The following is a description of a gene set: Mouse Gene Set: chr5C3 species: Mus musculus, and this is the list of marker genes: Gm19590 (predicted gene, 19590), Wdr19, Ppat, Gm25608, Chic2, Gsx2, Pdgfra (platelet derived growth factor receptor, alpha polypeptide), 1700071G01Rik, Cep135, Gm31049, Pea15b-ps, Gm15616, Ube2k, Dancr, Gm18593, Klhl5, Gm19560, 4930480C01Rik, Rasl11b, Gm26072, 1700025M24Rik, N4bp2, Tbc1d1, Gabra4, Arl9, Cwh43, Gm5297, Pgm2, 6720475M21Rik, Exoc1l, Gabrb1, Gm5867, Snora26, 0610040J01Rik, Tmem33, Gm6116, Gm6044, Gm22559, 5830416I19Rik, Apbb2, C030017G13Rik, Clock, 4930526M16Rik, Rhoh, Nwd2os, Gabra2, Usp46os1 (NCBI Gene Id 74299), Chrna9, Yipf7, C530043K16Rik, Gm43383, Txk, Srp72, Cnga1, D630030B08Rik, Gm15478, Scfd2, Gm43772, 4930425K10Rik, Tmem165, Gm43028, 1700019F05Rik, Slc10a4-ps, Gm23661 (NCBI Gene Id 115490305), Hopx, Olfr1401-ps1, Gm3822, Gm20647, Klf3, Igfbp7, Cracd (capping protein inhibiting regulator of actin), Dthd1, Shisa3, Gm34144, 9130230L23Rik, Noa1, Exoc1, Nipal1, 1700025A08Rik, A330058E17Rik (NCBI Gene Id 319553), Gm22273, Kit, Gm34583, Guf1, Usp46, Gm22929, Aasdh, Gm15824, Gm19583, 2310040G07Rik, Commd8, Gm42632, Spink2, Gm32780, Gm15831, Gm7494 (NCBI Gene Id 677181), Gabrg1, Apc-ps1, G6pd2, Sgcb, Smim14 (small integral membrane protein 14), Gm23605 (NCBI Gene Id 115486322), Polr2b, Uchl1os, A730089K16Rik, Gm43838, Bend4, N4bp2os, Chaer1, Mir574, Gm3687, 4930589O11Rik (NCBI Gene Id 78214), Rfc1, Gm24502, Tlr1, C330024D21Rik, Rest, Gm24399, Gm23067 (predicted gene, 23067), Gm6517, Gm6051, Gm20072, Nfxl1, Gm19060, Fryl, Kdr, Mir5098, Tmem156, Hopxos, Limch1, 1700126H18Rik, Lrrc66, Arap2, 3110031N09Rik, Gm26044, Grxcr1, 1110003F10Rik, Gm34648, Gm40309, D130004A15Rik, Gm34411, 1700027F09Rik, Ociad1, 1700112J05Rik, Gm9870, Ugdh, Fip1l1, 4933408A14Rik, Gm2040, Mir7025, Gm18345, Paics, Gm26761, Spmap2l, C230096K16Rik, Gm38562, Lias, Lnx1, Gm15617, 1700017L05Rik, Zar1, Rpl9, Gm26756, Gm26725, C78283, Nmu, Usp46os2, Klb, Zar1-ps, Gm15984, Uchl1, Phox2b, Ube2n-ps1, Atp10d (ATPase, class V, type 10D), Gm7467, Srd5a3, Pdcl2, Nsun7, Gm22011, Slc10a4, Cox7b2, Corin, Gm21011, Gm17906, Gm3716, Atp8a1, Gm15985, Gm25768, Gm33167, Dcun1d4, Rell1, Slain2, Fam114a1, Gm20033, 4930432L08Rik (NCBI Gene Id 74621), Gm35960, Gm15653, Ociad2, Pds5a, Gnpda2, Slc30a9, Kctd8, Nwd2, Tec (NCBI Gene Id 21682), Gm15477, Rbm47, Tlr6, Spata18, Gm42799, Gm15794